The following is a description of a gene set: Mouse Gene Set: WP_GLYCEROLIPIDS_AND_GLYCEROPHOSPHOLIPIDS studied in species Mus musculus Glycerolipids and glycerophospholipids, and this is the list of marker genes: Ptdss2, Dgat1, Plpp1, Pisd, Dgkz, Pla2g1b, Gpam, Pcyt2, Pnpla2, Chpt1 (choline phosphotransferase 1), Pemt, Pld1, Pnpla3, Agpat4, Gpat4, Ptdss1, Cdipt, Pcyt1a, Dgat2, Etnk1, Crls1 (cardiolipin synthase 1), Cds1, Chkb